Given this list of marker genes Nme1, Pnp, Itpa, Ada, Nt5c2, Slc28a3, Pnp2, Slc29a3, Nme2, Slc29a1, Slc28a2, Adk, here is a description of the gene set: Mouse Gene Set: REACTOME_RIBAVIRIN_ADME Ribavirin ADME species: Mus musculus